The following is a description of a gene set: studied in species Homo sapiens Genes predicted to be targets of miRBase v22 microRNA hsa-miR-6846-5p in miRDB v6.0 with MirTarget v4 prediction scores > 80 (high confidence targets). Human Gene Set: MIR6846_5P from publication Chen Y, Wang X (PMID 31504780), and this is the list of marker genes: HDAC7, ZC3H7B (zinc finger CCCH-type containing 7B), SYT7, NAT8L, SLC12A4, NCDN (neurochondrin), CHN1, NTSR1, CDK16, IGF2, NDEL1, B3GNT3, PRSS8, OSBP2, MPP2, SHB, FAM53B, TPSB2, CHP2, B3GNT7, NFIC, MYORG, RPUSD1, WNT1, ARG1, OR51E2, MMP15, FOXK1, INKA2 (NCBI Gene Id 55924), NOVA2, TNFRSF10B (TNF receptor superfamily member 10b), UBE3A, DDX39B, SCRT1, HNF4A, FGR, SIRPD, CASTOR1, CNN1, IL27, KCNAB2, SEC11A, ADGRL1 (NCBI Gene Id 79732), SCUBE3, MDGA1, ABTB2, CCDC97, PEDS1, GPANK1, BMERB1, SPRED3 (NCBI Gene Id 399473), NACC1, NCKAP5L, CMTM5, SLC8A2, KCNJ10, LFNG, SIT1, DISC1, CPLX1, SRD5A1, GALNT6, LSG1, MIDEAS, USH1G, IQSEC2, LRP10, MLF1, TCEANC2, GEMIN8, USP21, DVL3, EIF5A, NAPA, CRHR1 (corticotropin releasing hormone receptor 1), PPP1R9B, CPLX2 (NCBI Gene Id 84242), CASTOR2, SRRM3, PRKCA, PDGFB, TPSAB1, SCNN1A